Given this list of marker genes TCF25, TRIM44, PPIA, NMI, GABARAP, BIRC2, here is a description of the gene set: species: Homo sapiens Any process that modulates the rate, frequency or extent of protein K-48-linked ubiquitination, a protein ubiquitination process in which a polymer of ubiquitin, formed by linkages between lysine residues at position 48 of the ubiquitin monomers, is added to a protein. K48-linked ubiquitination targets the substrate protein for degradation. Human Gene Set: GOBP_REGULATION_OF_PROTEIN_K48_LINKED_UBIQUITINATION